The following is a description of a gene set: Human Gene Set: HP_HEREDITARY_NONPOLYPOSIS_COLORECTAL_CARCINOMA Hereditary nonpolyposis colorectal carcinoma species: Homo sapiens, and this is the list of marker genes: PDGFRL, MSH6, BRAF, CCND1, PLA2G2A, BUB1, POLD1, RAD54B, MLH3, TGFBR2, DLC1, PTPN12, AURKA, BAX, AXIN2, TLR2, EPCAM, BUB1B, MCC, NRAS, FLCN, CTNNB1, SRC, PIK3CA, PTPRJ, DCC, FGFR3, EP300, PMS2, APC, TP53, AKT1